Given this list of marker genes Aak1, Fyttd1, Phex, Nfam1, Mucl3, Il15ra, Galnt6, Jrk, Erg, Prune1, Pabpn1, Tcap, Nras, Treml2, Gabarapl1, Tgif2 (TGFB-induced factor homeobox 2), Hk2, Fam118a, Snx27, Nrl, Ptpa, Man1c1, Ptpro, Ube2j2, Gimap8, Synm (NCBI Gene Id 73939), Six3, Camta1, Fasl, Cyfip2, Ildr2, Ptgfrn, Pigr, Rab11fip3, Pheta1, S1pr3, Traf3, Mrfap1, Sox5, Prkag1, Commd7, Slc22a12, Tshz3, Slc10a2, Irf2, Robo4, Lrrc8e, Gkn1, Cacna1h, Vash1, Zfp940, Adcy6, Rps6ka2, Kcnq2, Zfp811, Bmf, Epb41l1, Klhl26, Foxo4, Ddx6, Fam3c, Cplx2, Mid2, H2-Eb2, Rassf1 (Ras association (RalGDS/AF-6) domain family member 1), Phf5a, Mmd2, Enpp5, Ubfd1, Il21r, Gcm1, Taf3, Atrn, Ensa, Cd300lg, Sema4g, Kif16b, Trps1, Insr, Ctif, Rnf20 (NCBI Gene Id 97155), Cotl1, Npr3, Zfp664, Cdv3, Vgll3, Spdye4b, Ank1, Fam124a, Crtc3, Brme1, Kcnq5, Cntn2, Nol6, Camk4, here is a description of the gene set: from publication Chen Y, Wang X (PMID 31504780) Mouse Gene Set: MIR_6919_3P studied in species Mus musculus Genes predicted to be targets of miRBase v22 microRNA mmu_miR_6919_3p in miRDB v6.0 with MirTarget v4 prediction scores > 80 (high confidence targets).